Given this list of marker genes Adora1, Grm2, Adora2b, Slc22a2, Ntsr1, Avp (NCBI Gene Id 11998), Cartpt, Slc43a1, Adora2a, Agt, Rgs2, Slc7a5, Ace2, Ptgs1, Rtn4, Dtnbp1, Arg2, Rab3gap1, Sncg, Aqp8, Gck, Kcnb1, Avpr1a, Grik1, Crhr2, Nr3c1, Stx1a, Rhag, Slc18a3, Hrh3, Prkcb, P2rx7, Crhr1, Drd3, Syt7, Cck, Gabbr1, Lep, Slc7a8, Syt4, Tor1a, Htr2a, Tacr2, Grk2, Cnr1, Slc17a8, Itgb1, Adora3, Flvcr2, Npy5r, Myo5a, Htr6, Arl6ip1, Chrna7, Slc36a2, Pcp4, Oxtr, Grin2b, Oxt, Th, Crh, Slc44a1, Nat8l, Psen1, Chrna4, Kcna2, Htr1a, Arg1, Slc44a2 (NCBI Gene Id 68682), Il1b, Slc12a2, Il1rn, Syt1, Gdnf, Slc18a1, Ddc, Chrna3, Tnf, Prkg1, Trh, Ptger3, Plcd1, Slc38a1, Ghsr (growth hormone secretagogue receptor), Syt11, Kmo (NCBI Gene Id 98256), Slc15a1, Cxcl12 (C-X-C motif chemokine ligand 12), Chrnb2, Rab3a, Chrna6, Sdhd, Agtr2, Npy2r, Flvcr1, Oprk1, Arl6ip5, Entpd1, Htr2c, Ffar3, Htr1b, Per2, Rab3b, Slc18a2, Pink1, P2ry12, Cltrn, Chga, P2ry1, Slc43a2, Arhgef11, Drd2, Sv2a, Slc38a3, Septin2, Rgs4, Dpysl2, Snca, Slc38a2, Grm7, Aqp9, Stxbp1, Abat, Slc6a14, Slc6a1, Slc22a16, Cacna1a, here is a description of the gene set: studied in species Mus musculus Mouse Gene Set: GOBP_AMINE_TRANSPORT The directed movement of amines, including polyamines, organic compounds containing one or more amino groups, into, out of or within a cell, or between cells, by means of some agent such as a transporter or pore.